Given this list of marker genes Il1rn (NCBI Gene Id 320052), Il1rapl1, Nlrp2, A2m, Hax1, Il1r1, Il1r2, Trim16, here is a description of the gene set: studied in species Mus musculus Mouse Gene Set: GOMF_INTERLEUKIN_1_BINDING Binding to interleukin-1.